The following is a description of a gene set: Genes up-regulated in unstimulated monocytes versus macrophages incubated with CSF1 at day 7. from publication Martinez FO, Gordon S, Locati M, Mantovani A (PMID 17082649) Human Gene Set: GSE5099_UNSTIM_VS_MCSF_TREATED_MONOCYTE_DAY7_UP studied in species Homo sapiens Monocytes mature tom acrophages in the presence of the lineage determining cytokine M-CSF. They can be further polarized into M1 or M2 macrophages with distinct functional properties. We used microarrays to detail the global programme of gene expression underlying macrophage maturation and polarization and identified distinct classes of up-regulated genes during this process., and this is the list of marker genes: ABHD17B, EXOSC1, SH3GLB1, APPL1, TEX30, TLR7, CXXC5, BAG1 (BAG cochaperone 1), NASP, TRMT2B, RPL26, SACM1L, WASHC4, DAZAP2, ESF1, CD28, YIPF5, ANKRD24, DUS1L, PNN, USP34, TMEM64, CDK1, KATNBL1, SS18L2, TMEM167A, CNBP, IDS, SESN3, NDUFAF4, NBN, WAC, IL10RB, HERC2, POGLUT3, DPY19L4, RLF, H2AZ1, OSBPL9, EIF3L, RRM2B, ARHGAP30, PIGF, EIF3A, NUP37, PIGX, TMEM107 (transmembrane protein 107), AP3S1, SUCO, DNAJC15, CMPK1, RELCH, ZNF445, ZBTB1, GNG2, TGM4, PNP, PIGP, MEMO1, EIF1B, NIFK, BTBD1, VPS54, LARGE1, KPNA3, ANKRD10, ADGRF5, STRBP, HNRNPA1, CCNL2, METTL15, PCMTD1, ZNF318, CDC37L1, NUDT12 (NCBI Gene Id 83594), DAPP1, OLA1, NSFL1C, PBK, JADE1, METAP2, ANAPC4, VAMP7, SRSF10, UTRN, COMMD6, RMDN3 (NCBI Gene Id 55177), NABP1, NCOA6, POMP, PSMD10, RBM34, CEP41, UBE2L3, CCT5, PXYLP1, CREBZF, PCMT1, HPRT1, ARFGEF1 (NCBI Gene Id 25860), GINS1, VPS41, RDX, EMC3, NEK7, TMEM168, PPP2R5C, AKAP9, RPL39L, ARGLU1, BANF1, COX4I1, LRRC40, POLR1F, CTBS, SFXN4, RPL24, EFCAB14, ZBTB33, RPL23A, GPM6B, FNTA, ZHX1, MTHFD1, SQLE, EIF3E, SURF1, MAPK9, NDUFB9 (NADH:ubiquinone oxidoreductase subunit B9), LRIF1, NOC3L, NSD3, ATP5MK, STRADB, ECI2, SNX5, PPP1CC, HSPA4L, VPS35, GABPB2, DPP4, OSER1, RNASE6, CLEC4M, MMUT, FMNL2, GCLM, CHD9, FEM1C, SNX2, PLPP5, LRRC72, MRPL39, GABPA, CDC5L, ERO1B, CPSF3 (cleavage and polyadenylation specific factor 3), MID1, UBE2D3, TPP2, RSRC1, RPL17, AKIRIN1, MED10, MGA, PSMC2, ATP11B (ATPase phospholipid transporting 11B (putative)), FAM98A, ZNF281, TSN, RHD, AGO2, ETNK1, ZNF157, PPM1H (protein phosphatase, Mg2+/Mn2+ dependent 1H), SEC63, PHOSPHO2, TRAM1, RAB9A, FAM162A, SLC7A9, NSMCE4A (NSE4 homolog A, SMC5-SMC6 complex component), ANKHD1, ALDH18A1, NLRC5, UBR3, TBRG1, SHMT1, HSPA13, RNMT, MFSD14A, IFTAP, TSC22D2, PCLAF, ERI2, KCTD12, PHF10, CHURC1, NOL7, SENP7